Given this list of marker genes Fli1, Tek, Tgfbi, Notch4, Slc7a1, Cd34, Tgfbr2, Flt1, Pecam1, Vwf, Anxa3 (NCBI Gene Id 11745), Lama4, Kdr, Myh9, Egfl7, Dll4 (delta like canonical Notch ligand 4), Eng, Acvrl1, Ttyh2, here is a description of the gene set: studied in species Mus musculus Mouse Gene Set: HEVNER_CORTEX_VASCULAR_ENDOTHELIAL_CELLS Genes selectively expressed by blood vessel endothelial cells in embryonic day 14.5 mouse cortex. from publication Bedogni F, Hevner RF (PMID 34321999)